Given this list of marker genes LAMA3 (laminin subunit alpha 3), ROPN1L, ANGPTL4, CXCL1, AREG, DST, EFNB1, ITGB4, FGFBP1, CA2, KLK10, EIF2B3, SERPINB2, FXYD3, S100A2, TENM2, FBN2, KLK5, SERPINB5, CSF2, ANXA8L1, PTPRK, TM4SF1, LAMC2 (laminin subunit gamma 2), TRIM29, AKR1C1, B3GNT5, GABRE, MMP14, SAA1, LMTK3, CALML3, KRT13, LIPG, ITGA6 (NCBI Gene Id 3655), PTHLH, PPP1R14C, PTGS2, COL7A1, TP63, PI3, MAOA, PGAP4, F2RL1, S100A9, KLHL13, BARX2, AKR1C3, CYP26A1, GPX2, S100A8, COL17A1, SERPINE1, KRT17, DUSP6, CAV2, FASN, CAV1 (caveolin 1), ALDH1A3 (aldehyde dehydrogenase 1 family member A3), GJB5, KRT6B, CSTA, DSC3, SPRR2C, TFPI2, LGALS7, MRAP2, CLDN8, ADRB2, DMRT2, CDH3, KRT5, SPRR1B, HAS3, KRT1, here is a description of the gene set: studied in species Homo sapiens Intermediate filaments. Human Gene Set: MODULE_154